The following is a description of a gene set: species: Mus musculus The assembly and organization of the sperm mitochondrial sheath, the tightly packed helical sheath of ATP-producing mitochondria restricted to the midpiece of the sperm flagellum. Mouse Gene Set: GOBP_SPERM_MITOCHONDRIAL_SHEATH_ASSEMBLY, and this is the list of marker genes: Lrrc46, Misfa, Vdac3, Armc12, Tbc1d21, Cfap58, Klc3, Gk2